The following is a description of a gene set: Human Gene Set: HP_CHILBLAINS Chilblains, also called perniosis, are an inflammatory skin condition related to an abnormal vascular response to the cold. We are unaware of a reliable estimate of incidence. It typically presents as tender, pruritic red or bluish lesions located symmetrically on the dorsal aspect of the fingers, toes, ears and nose. Less commonly, reports describe involvement of the thighs and buttocks. The lesions present hours after exposure to cold and usually resolve spontaneously in one to three weeks. Chilblains species: Homo sapiens, and this is the list of marker genes: IFIH1, ADA2, RNU7-1, RNASEH2A, LSM11, C1QB, RNASEH2C, RNASEH2B, TREX1, ADAR, SAMHD1, DNASE2